The following is a description of a gene set: Genes predicted to be targets of miRBase v22 microRNA hsa-miR-203a-5p in miRDB v6.0 with MirTarget v4 prediction scores > 80 (high confidence targets). from publication Chen Y, Wang X (PMID 31504780) species: Homo sapiens Human Gene Set: MIR203A_5P, and this is the list of marker genes: MAP4K3, KLF11, ANKRD44, EEIG1, TAMALIN, PPTC7, DTNA, LASP1, CCNG1, UBE2D3, RTL6, EPHA3, PHLDA1, CEMIP, CREBRF, C1QTNF6, CFAP263, ZBTB4, CSGALNACT2, TBP, ABHD12B, TSC22D2, SH3BGRL (SH3 domain binding glutamate rich protein like), CDKL2, ABHD3, ELOVL5, RNF11, MEX3C, CNOT6L, IGF1R, ZC3H6, WIPF1, ERBIN, KBTBD2 (kelch repeat and BTB domain containing 2), ZNF800, COLQ, CCL2, EPC1, VIT, JAG1, BTG2, FRAS1, PFKFB3, ABCC4, TUBD1, ARMC1, MICAL3, SINHCAF, CDH6, ZNRF3 (zinc and ring finger 3), NT5E, PTPN14, DIP2B, AARS1, CCER1, NBPF1, CATSPERE, APAF1, PPFIA2, CDKL1